The following is a description of a gene set: Human Gene Set: SUZUKI_AMPLIFIED_IN_ORAL_CANCER species: Homo sapiens Array-based comparative genomic hybridization (array-CGH) has good potential for the high-throughput identification of genetic aberrations in cell genomes. In the course of a program to screen a panel of oral squamous-cell carcinoma (OSCC), cell lines for genomic copy-number aberrations by array-CGH using our in-house arrays, we identified a 3-Mb homozygous deletion at 10p12 in 1 of 18 cell lines (5.6%). Among seven genes located within this region, expression of PRTFDC1 mRNA was not detected in 50% (9/18) or decreased in 5.6% (1/18) of OSCC cell lines, but detected in normal oral epithelia and restored in gene-silenced OSCC cells without its homozygous loss after treatment with 5-aza-2'-deoxycytidine. Among 17 cell lines without a homozygous deletion, the hypermethylation of the PRTFDC1 CpG island, which showed promoter activity, was observed in all nine cell lines with no or reduced PRTFDC1 expression (52.9%). Methylation of this CpG island was also observed in primary OSCC tissues (8/47, 17.0%). In addition, restoration of PRTFDC1 in OSCC cells lacking its expression inhibited cell growth in colony-formation assays, whereas knockdown of PRTFDC1 expression in OSCC cells expressing the gene promoted cell growth. These results suggest that epigenetic silencing of PRTFDC1 by hypermethylation of the CpG island leads to a loss of PRTFDC1 function, which might be involved in squamous cell oral carcinogenesis. from publication Suzuki E, Imoto I, Pimkhaokham A, Nakagawa T, Kamata N, Kozaki KI, Amagasa T, Inazawa J (PMID 17599052) High-level amplifications detected in oral squamous cell carcinoma (OSCC) lines by array-CGH analysis., and this is the list of marker genes: FGF3, EGFR, CCND1, BCL9, SUPT5H, MITF, MMP7, MMP1, PGR, FGF4, PTGDR, BCL7A, CCND2, FGF6, GAS6, YAP1, PTH